Given this list of marker genes Selenop (selenoprotein P), Uba52, Klf2, Ccr2, Eif3f, Pnrc1, Tsc22d1, Rpgrip1, Ctsl, Ccr9, Xist, Clec12a (NCBI Gene Id 232413), Dap (death-associated protein), Jund, H2bc27, Luc7l2 (NCBI Gene Id 75005), Spns3, Nsa2, Mvb12a, Mtss1, Fos, Btg1, Pafah1b3, Dntt, Ptpre, Naca, Eif3h, Zbtb20, Smad7, Eef2, Rgs10, Syk (spleen tyrosine kinase), Grcc10, Ppfia4, Nop53, H2az2, Septin4, Eif3e, Itm2b, Smim14, Fyb1, Atp1b1, Trf, Hvcn1, Khk, Rack1, Cdip1, Ivns1abp, Cox6a2 (NCBI Gene Id 12862), Timp2 (NCBI Gene Id 52894), Arl5c, Klf13, Klhl24, Cox7a2l, Fuca2, Fau, Bst2, Btg2, Fyn, Tmem50a, Jun, Apobec3 (NCBI Gene Id 80287), Snx29, Cacna1e, Unc93b1 (unc-93 homolog B1, TLR signaling regulator), Haus3, Clk1, Vsir (V-set immunoregulatory receptor), Gmfg, Jakmip1, Zfp36l1, Cmah, Serinc5, Macf1, Rabgap1l, Ramp1, Ddx5, Pgls, Ypel3, Mxd4, Tsc22d3, Smim5, Ptpn18, Klrd1, R3hdm4, Eef1a1, Cd7, here is a description of the gene set: Mouse Gene Set: CUI_PDC_IL3_RESPONSE_DN Cytokines mediate cell-cell communication in the immune system and represent important therapeutic targets. A myriad of studies have highlighted their central role in immune function, yet we lack a global view of the cellular responses of each immune cell type to each cytokine. To address this gap, the authors created the Immune Dictionary, a compendium of single-cell transcriptomic profiles of more than 17 immune cell types in response to each of 86 cytokines (>1,400 cytokine-cell type combinations) in mouse lymph nodes in vivo. A cytokine-centric view of the dictionary revealed that most cytokines induce highly cell-type-specific responses. For example, the inflammatory cytokine interleukin-1β induces distinct gene programmes in almost every cell type. A cell-type-centric view of the dictionary identified more than 66 cytokine-driven cellular polarization states across immune cell types, including previously uncharacterized states such as an interleukin-18-induced polyfunctional natural killer cell state. Genes negatively differentially expressed in cell type: pDC (plasmacytoid dendritic cell) upon treatment with cytokine: IL-3 in mouse lymph nodes in vivo. species: Mus musculus from publication Cui A, Huang T, Li S, Ma A, Pérez JL, Sander C, Keskin DB, Wu CJ, Fraenkel E, Hacohen N (PMID 38057668)